Given this list of marker genes PSG5, TIMP2, HSD17B2, GPC3, SVEP1, PSG3, PSG9, PLAC1, PSG4, ALPP, PSG6, EBI3, CYP19A1, EGFL6, GH2, KISS1, IGFBP1, PAGE4, HSD3B1, LEP, CAPN6, PSG2, PAPPA, HSD17B1, ADAM12, PSG7, TAC3, GDF15, CRH, MMP11, GCM1, LGALS14, IGF2 (NCBI Gene Id 492304), PSG1, PAPPA2, here is a description of the gene set: Neighborhood of IGFBP1 Human Gene Set: GNF2_IGFBP1 studied in species Homo sapiens Neighborhood of IGFBP1 insulin-like growth factor binding protein 1 in the GNF2 expression compendium